Given this list of marker genes Mir326, Nlrp3, Brd2, Nfkbiz, Opa1, Nfkbid, Ep300, Il23a, Malt1, Brd4, here is a description of the gene set: Any process that activates or increases the frequency, rate or extent of T-helper 17 cell differentiation. studied in species Mus musculus Mouse Gene Set: GOBP_POSITIVE_REGULATION_OF_T_HELPER_17_CELL_DIFFERENTIATION